Given this list of marker genes LAMB3, SYTL3, MARCHF3, PLAUR, NFKBIE, YWHAG, GDF15, ZC3H12A, VEZT, BIRC3, SEC14L2, PIK3IP1, ADM, CBR3, PIMREG, SERPINE1, SLC7A1, CLEC4E, FBXO32, KIF2C, HMOX1, STEAP3, C15orf48 (chromosome 15 open reading frame 48), MAP3K14, TGM2, EBP, TM4SF1, RBM3, SERPINB8, TYMS (NCBI Gene Id 7298), ASPH, FABP6, RRAGD, KDM3A, SELENOH, CXCL1, EDN2, CXCL5, HMGA2, PHLDA2, PPP1R15A, LAMC2, EDN1, ANP32E, SPINK1 (NCBI Gene Id 6690), RGPD4 (RANBP2 like and GRIP domain containing 4), COL7A1, NRP2, NECAP2, TM4SF19, IL1RAP, JUNB (JunB proto-oncogene, AP-1 transcription factor subunit), INSIG1, here is a description of the gene set: The hypoxia-inducible transcription factors (HIFs) directly and indirectly mediate cellular adaptation to reduced oxygen tensions. Recent studies have shown that the histone demethylase genes JMJD1A, JMJD2B, and JARID1B are HIF targets, suggesting that HIFs indirectly influence gene expression at the level of histone methylation under hypoxia. In this study, we identify a subset of hypoxia-inducible genes that are dependent on JMJD1A in both renal cell and colon carcinoma cell lines. JMJD1A regulates the expression of adrenomedullin (ADM) and growth and differentiation factor 15 (GDF15) under hypoxia by decreasing promoter histone methylation. In addition, we demonstrate that loss of JMJD1A is sufficient to reduce tumor growth in vivo, demonstrating that histone demethylation plays a significant role in modulating growth within the tumor microenvironment. Thus, hypoxic regulation of JMJD1A acts as a signal amplifier to facilitate hypoxic gene expression, ultimately enhancing tumor growth. Genes dependent on KDM3A for hypoxic induction in RCC4 cells (renal carcinoma) expressing VHL. species: Homo sapiens Human Gene Set: KRIEG_HYPOXIA_VIA_KDM3A from publication Krieg AJ, Rankin EB, Chan D, Razorenova O, Fernandez S, Giaccia AJ (PMID 19858293)